The following is a description of a gene set: part of: Hemostasis Under normal conditions the vascular endothelium supports vasodilation, inhibits platelet adhesion and activation, suppresses coagulation, enhances fibrin cleavage and is anti-inflammatory in character. Under acute vascular trauma, vasoconstrictor mechanisms predominate and the endothelium becomes prothrombotic, procoagulatory and proinflammatory in nature. This is achieved by a reduction of endothelial dilating agents: adenosine, NO and prostacyclin; and by the direct action of ADP, serotonin and thromboxane on vascular smooth muscle cells to elicit their contraction. Cyclooxygenase-2 (COX-2) and endothelial nitric oxide synthase (eNOS) are primarily expressed in endothelial cells. Both are important regulators of vascular function. Under normal conditions, laminar flow induces vascular endothelial COX-2 expression and synthesis of Prostacyclin (PGI2) which in turn stimulates endothelial Nitric Oxide Synthase (eNOS) activity. PGI2 and NO both oppose platelet activation and aggregation, as does the CD39 ecto-ADPase, which decreases platelet activation and recruitment by metabolizing platelet-released ADP. Reactome Pathway: Platelet homeostasis studied in species Homo sapiens, and this is the list of marker genes: PRKG2, ORAI2, GNG12, CALM1, GUCY1B1, GNG13, LRP8, TRPC3, NOS1, ITPR2, GUCY1B2, PDE10A, PTPN6, PDE1A, GNG10, GNGT2, PPP2R5A, IRAG1, KCNMB3, P2RX6, FGR, P2RX7, GNB3, ATP2A2, PDE9A, GNG7, KCNMB4, PPP2CA, GNB1, STIM1, KCNMA1, KCNMB1, PPP2CB, TRPC7, ATP2B4, SLC8A1, GNG11, PTGIR, PLA2G4A, PPP2R5D, ATP2B3, PAFAH2, GNG5, GNG3, PRKG1, GNB4, ITPR3, P2RX2, PDE2A, GNG8, PPP2R1B, GNB5 (NCBI Gene Id 82962), PPP2R5C, GNG4, SLC8A2, P2RX4, NOS2, GUCY1A1, PTPN11, SRI, GNGT1, ATP2B1, NOS3, MAPK14, ATP2A3, GNAS, ITPR1, PDE5A, PPP2R1A, SLC8A3, P2RX3, P2RX5, ORAI1, TRPC6, PPP2R5E, PECAM1, PDE1B, PDE11A, GNB2, GNG2 (G protein subunit gamma 2), ATP2A1, APOB, ATP2B2, P2RX1, GUCY1A2, PPP2R5B, KCNMB2